Given this list of marker genes CANX, NFYA, RAB11A, DNAJB6, IGKC, SLC2A3, ANP32E, AMFR, PTPN12, IL1B, ZBED4, IMPA1, ATP6V1G1, BCLAF1 (NCBI Gene Id 9774), AHR, PPP1R10, RHEBP1, ITSN2, PAX8, MIR22HG, TRAF3IP2, ABL1, UBE2E3, PYROXD1, MAPK14, FLI1, DDX5, EID1, TRAF3IP3, CDC42EP3, SQLE, LYN, MKNK1, USP7, ETFA, LY96, ANXA5, CD53, TENT4A, HAUS2, ARFGAP3, GADD45B, here is a description of the gene set: Genes downregulated in peripheral blood lymphocytes (PBL) from patients with well functioning kidneys more than 1-year post transplant compared to those from normal living kidney donors. from publication Flechner SM, Kurian SM, Head SR, Sharp SM, Whisenant TC, Zhang J, Chismar JD, Horvath S, Mondala T, Gilmartin T, Cook DJ, Kay SA, Walker JR, Salomon DR (PMID 15307835) A major challenge for kidney transplantation is balancing the need for immunosuppression to prevent rejection, while minimizing drug-induced toxicities. We used DNA microarrays (HG-U95Av2 GeneChips, Affymetrix) to determine gene expression profiles for kidney biopsies and peripheral blood lymphocytes (PBLs) in transplant patients including normal donor kidneys, well-functioning transplants without rejection, kidneys undergoing acute rejection, and transplants with renal dysfunction without rejection. We developed a data analysis schema based on expression signal determination, class comparison and prediction, hierarchical clustering, statistical power analysis and real-time quantitative PCR validation. We identified distinct gene expression signatures for both biopsies and PBLs that correlated significantly with each of the different classes of transplant patients. This is the most complete report to date using commercial arrays to identify unique expression signatures in transplant biopsies distinguishing acute rejection, acute dysfunction without rejection and well-functioning transplants with no rejection history. We demonstrate for the first time the successful application of high density DNA chip analysis of PBL as a diagnostic tool for transplantation. The significance of these results, if validated in a multicenter prospective trial, would be the establishment of a metric based on gene expression signatures for monitoring the immune status and immunosuppression of transplanted patients. Human Gene Set: FLECHNER_PBL_KIDNEY_TRANSPLANT_OK_VS_DONOR_DN studied in species Homo sapiens